Given this list of marker genes ATPSCKMT, ISCU, TOR2A, GNB5, FGF12, TSPAN13, LACRT, PRKD1, TMBIM6, ACTN4, KCNAB2, GPR35, KCNJ4, CACNA1F (NCBI Gene Id 778), GRIN2C, LIME1, PTPN6, PSEN2, DIAPH1, ASIC2, GALR2 (galanin receptor 2), STRIT1, CRACR2A, KCNAB3, KCNE5, ANK3, PPP3R1, HEPH, DRD1, BDKRB1, F2RL3, STAC, CACNA1D, ATP1B1, SCN5A, MIR208B, SPHK2 (NCBI Gene Id 56848), FXYD4, ATP4A, CASQ2, ATP2A1, CACNG1, KCNIP2, KCNJ10, KCNJ3, CACNG6, VAMP2, FXYD5, LRRC52, OXSR1, PHB2, CEMIP, RGS9, FKBP1B, SCN10A, GSTM2, SUMO1 (NCBI Gene Id 7341), DHRS7C, FXYD6P3, FMR1, IFNG, GSTO1, ATP1B2, CALHM1, MIR448, KCNE2, CRBN, PLN, KCNS3, PPIF, AKAP7, KCNJ18, MIR200C, EDN3, MIR499A, TMEM38B, KCNJ11, KCNIP4 (potassium voltage-gated channel interacting protein 4), HAMP, CHD7, KCNH2, MIR26A1, DMD, KEL, SNTA1, MIR133A1, MIR103A1, MIR208A, ATP1B3, FKBP1A, ITGB3, G6PD, KCNK16, KCNJ5, AHNAK, ATG5 (NCBI Gene Id 9474), MIR212, PIK3CG, DPP10, NPSR1, WNK3, FXYD3, P2RX4, NPPA, NOS1AP (nitric oxide synthase 1 adaptor protein), NGF, PTK2B, KCNJ9, TLR9, FXYD6, FGF13, EPO, CACNB3, CXCR3, MIR29B1, UBASH3B, RGS4, ABL1, KCNN4, PPP3CA, KCNRG, VDAC1, KCNG1, KCNE3, MIR30D, IL13, NOS1, BIN1, GRIN2A, WNK2, SPG7, ANO6, MS4A1, SRI, JPH3, ATP1A2, P2RX3, AFG3L2, NEDD4, MIR93, ATP2B4, EDN1, DLG1, CASQ1, AMIGO1, TMEM38A, COX17, LYN, CALM2, GRIN2B, JPH1, WNK1, KCNJ6, MCUB, TRPC3, PPP3CB, TMSB4X, PDE4B, GNB2, UBR3, LRRC55, JPH2, BAX, TRDN, WWP2 (NCBI Gene Id 116013), SELENON, CD4, KCNJ1, CACNB4, SLC31A2, KCNAB1, P2RX7, THY1, KCNG3, PRNP, CRHR1, CXCL11, MMP9, P2RX2, PRKCE, CD63, WNK4, GRIN2D (glutamate ionotropic receptor NMDA type subunit 2D), F2, HAP1, KCNG4, CXCL9, CLIC2, DPP6, STAC2, JPH4 (junctophilin 4), CXCL10, F2R, KCNJ14, KCNQ1, LRRC38, AKAP5, GPER1, CALM1, FLNA, SCN1B, AGT, SLMAP, KCNJ16, STK39, CORO1A, VMP1, P2RX5, XCL1, CAB39, MIR21, SNCA (NCBI Gene Id 6622), PPP3R2, BCL2, KCNJ15, KCNJ2 (potassium inwardly rectifying channel subfamily J member 2), CD19, SLC26A5, OPRK1, FHL1 (four and a half LIM domains 1), BAK1, STAC3, CALCA, PDPK1, BPIFA1, APLNR, AKAP6, CACNB2, KCNIP1, CAV3, ADCYAP1R1, REM1, TRPC1 (NCBI Gene Id 7220), GRP, OSR1, KCNN2, TESC, TCIRG1, CACNB1, CFTR, PPP3CC, RANGRF, EDNRA, MIR192, ASPH, P2RY6, GAL, SLN, YWHAQ, GRM6, GRIA1, KCNJ13, TMC1, MIR1-1, CYBA, CAMK2D, CTSS, GRIN1, CX3CL1, LRRC26, ABCC9, PLCG1, UCP2, MIR328, TMC2, TRPC6, APP, CACNA1C, PTPN3, TCAF2, ANK2, MIR210, SLC8A1, SESTD1, PRKACA, KCNS1, PLA2G1B, STIM2, KCNC1, RYR2, KCNC2, GOPC, SLC30A1, ACTN2, HTT, TCAF1, FXYD7, TGFB1, PML, NTSR1, KCNJ12, KCNE1, KCNIP3, NEDD4L, YWHAE, COMMD1, FXYD1, CHP1, FYN, UBQLN1, P2RX1, CAV1, STOM, FXYD2, HPCA, PCSK9, METTL21C, STIMATE, KCNS2, NIPSNAP2, CALM3, CACNA2D1, KCNJ8, STIM1, CAPN3, PDE4D, CBARP, MIR24-1, UTRN, HRC, LCN2 (lipocalin 2), here is a description of the gene set: Any process that modulates the frequency, rate or extent of the directed movement of ions from one side of a membrane to the other. Human Gene Set: GOBP_REGULATION_OF_MONOATOMIC_ION_TRANSMEMBRANE_TRANSPORT species: Homo sapiens